Given this list of marker genes CNOT4, ARPC3, MTHFD2, RFC1 (NCBI Gene Id 5981), DAG1, SNX30, USP37, ZNF117, ZNF107, PIK3C2A, MTMR12, RHOBTB1, RPA1, SHC2, BHLHE40, POLR1C, AGO3, PHC3, MRTFB, UBE2E3, IGF2R, MLLT10, ZNF737, BCLAF3, PTBP3, PPARGC1A, TAF4, HECTD2, RRAGA, SACM1L, PTCH2, FAM98A, XYLT1, here is a description of the gene set: from publication Chen Y, Wang X (PMID 31504780) Human Gene Set: MIR4484 Genes predicted to be targets of miRBase v22 microRNA hsa-miR-4484 in miRDB v6.0 with MirTarget v4 prediction scores > 80 (high confidence targets). studied in species Homo sapiens